The following is a description of a gene set: Human Gene Set: HP_WRIST_HYPERMOBILITY Wrist hypermobility species: Homo sapiens The ability of the wrist joints to move beyond their normal range of motion., and this is the list of marker genes: COL6A2, COL6A3, HYAL1, COL6A1, RNF13, PYCR2, COL12A1